Given this list of marker genes CD320, MTRR, LDLRAP1, CUBN, MMADHC, MTR (5-methyltetrahydrofolate-homocysteine methyltransferase), LMBRD1, ABCD4, PRSS3, CTRB2, LRP2, CTRB1, AMN, CBLIF, MMUT, TCN1, MMAA, TCN2, MMACHC, MMAB, PRSS1, ABCC1, here is a description of the gene set: Reactome Pathway: Cobalamin (Cbl, vitamin B12) transport and metabolism part of: Metabolism of water-soluble vitamins and cofactors Vitamin B<sub>12</sub> (cobalamin) is a water soluble vitamin, consisting of a planar corrin ring coordinating with a cobalt atom through four nitrogen atoms. A 5,6 dimethylbenzamidizole base coordinates with the cobalt atom in the lower axial position. Groups that can coordinate with the cobalt atom in the upper axial position include methyl (methylcobalamin, MetCbl), adenosyl (adenosylcobalamin, AdoCbl) and cyano (cyanocobalamin (CNCbl)). Only bacteria and archaea synthesise cobalamin so humans need a dietary intake to prevent deficiency. Food derived from animals provides cobalamins (RCbl) including MeCbl and AdoCbl. CNCbl, a semi synthetic form of the vitamin produced from bacterial hydroxocobalamin is provided by many pharmaceuticals, supplements, and food additives.<p>Cbl derivatives function as cofactors in two reactions, AdoCbl in the conversion of homocysteine to methionine and MetCbl in the conversion of L-methylmalonyl CoA to succinyl CoA. Both reactions are essential for normal human function, however, and defects in the steps by which Cbl or CNCbl is taken up from the diet, transported to metabolically active cells, and transformed to AdoCbl and MeCbl are associated with severe defects in blood formation and neural function.<p>The overall process of Cbl utilization is presented here in three parts: its uptake from the diet into gut enterocytes, its release into the blood, circulation within the body (including renal re-uptake), and delivery to the cells where it is used, and its metabolism in those cells to generate AdoCbl and MeCbl. species: Homo sapiens